Given this list of marker genes Eif1ax, Eif2ak4 (eukaryotic translation initiation factor 2 alpha kinase 4), Nsun3, Ssb, Mars1, Gtsf1, Elp5 (elongator acetyltransferase complex subunit 5), Gtpbp1, Trmt9b, Alkbh1, Rpusd4, Trnt1, Cars1, Fars2 (NCBI Gene Id 77901), Eif1a, Trmt10b, Iars2, Aars1, Eif2s3y, Trmt10a, Slfn2, Mtrfr, Dalrd3, Eef1a1, Mtres1, Trmt11, Trmt1, Nsun4, Yrdc, Qtrt2, Ptrh1, Trmt1l, Nat10, Aimp1, Sars2, Pus1, Ighmbp2, Rpl6, Iars1, Sars1, Farsa, Yars1, Elp3, Nsun2, Dus2, Eefsec, Dtd2, Sepsecs, Rps10, Rars1, Elp1, Ptcd1, Nsun6, Wdr6, Tert, Yars2, Xpot, Eif2s3x, Slfn8 (NCBI Gene Id 436462), Nemf, Alkbh8, Hsd17b10, Slfn9, Trnau1ap, Xpo5 (exportin 5), Kars1, Aars2, Dtd1, Mettl1, Thumpd3, Trmt10c, Ctu1, Tyw5, Ctu2, Eif2a, Trmu, Pstk, Ears2, Mrps27 (mitochondrial ribosomal protein S27), Eif5b, here is a description of the gene set: Mouse Gene Set: GOMF_TRNA_BINDING species: Mus musculus Binding to a transfer RNA.